The following is a description of a gene set: Human Gene Set: GOBP_POSITIVE_REGULATION_OF_DEVELOPMENTAL_GROWTH species: Homo sapiens Any process that activates, maintains or increases the rate of developmental growth., and this is the list of marker genes: RIMS2, SYT1, DSCAM (NCBI Gene Id 1826), WNT2, GOLGA4, MIR590, ATP8A2, STAT5B, ZP3, MIR208A, CRABP2, WT1, PUM2, HEY2, PEX5, NIPBL, MIR19B1, CAPN3, SLC23A2, SYT4, LEP (leptin), L1CAM, SMURF1, MACF1, SPTBN4, GHRL, ITSN2, CREB1, DRD2, ERBB4, FGF8, YBX3, DIO3, FGFR1, ACACB, PAK1, GH1, BMPR2, MIR204, MYOD1, SEMA5A, BCL11A, GATA6, ISLR2, AKAP6, MAPK14, NACA, AGRN, MIR199A1, RIMS1, PPIB (peptidylprolyl isomerase B), AKT1, IGF2, WNT3, IST1, NEDD4L, ADNP, CPNE6, NGF, MIR509-1, WNT3A, MAP1B, YAP1, CPNE9, TWF2 (twinfilin actin binding protein 2), FN1, PLAA, PIM1, BBS2, ADCY10, VEGFA, SLC6A3, SYT2, TRPV2, TBX2, NTRK3, EDN1, HLX, PPARD, GHRH, MTM1, PARP2, PRKN, CPNE5 (copine 5), ANAPC2, RND2, INSR, ZFPM2, MEF2C (NCBI Gene Id 4208, myocyte enhancer factor 2C), FGF9, MAPT, AGR2, LIMK1 (NCBI Gene Id 3984), IGF1, VIL1 (NCBI Gene Id 7429), HMGA2, NTN1, PLS1, CDKL5, MIR222, PLCB1, ARX, SEMA7A, CXCL12, CACNA2D2, HSF1, EZR, MAP3K13, TRPC5, PAFAH1B1, DLL1, GHSR, RBPJ, BASP1, CDH4, SEMA4D, RASAL1, MKKS, MUL1, RNF157, MIR17HG, CACNG7, NRP1, BBS4, MIR548C, MEGF8, TBX5, TNFRSF12A, CHD7, CCNB1, SMO, CSF1, SMAD7, ACTN3, EFNA5, RUFY3 (NCBI Gene Id 441022), FGFR2, FGF2, PROX1, SERP1, SRF, NOTCH1, BMP10, TGFBR3, BDNF, FOXS1, BMPR1A, CDK1, SOX15, GHRHR, HOPX, GPAM, RAG2, ZFYVE27, SYT3, NRG1, MIR19A, TBX20 (NCBI Gene Id 57057), POU3F2, GLI1, SHTN1, STAT5A, BCL2, DISC1, POU4F2, SYT14P1 (synaptotagmin 14 pseudogene 1), SYT17, LPAR3, SASH3, IL7, GHR, GPR21, GDI1, UNC13A